The following is a description of a gene set: The epithelial cell differentiation process in which a relatively unspecialized cell acquires specialized features of an acinar cell, a secretory cell that is grouped together with other cells of the same type to form grape-shaped clusters known as acini. studied in species Mus musculus Mouse Gene Set: GOBP_ACINAR_CELL_DIFFERENTIATION, and this is the list of marker genes: Zfp800, Prox1 (prospero homeobox 1), Ctnnb1, Clcn2, Nr5a2